Given this list of marker genes Pycr3, Gls2, Glul, Pycr2, Cln3, Pycr1, Agmat, Gls, Arg1, Ass1, Ldc1, Mecp2, Otc, Hal, Atcay (ataxia, cerebellar, Cayman type), Slc38a1, Nags, Bloc1s6, Noxred1, Cps1, Dao, Adhfe1, Got1, Nos3, Odc1, Mthfsl, Nit2, Amdhd1, Fah, Phgdh, Fpgs, Aldh4a1, Apc, Slc7a11, Gclc, Prodh, Nos2, Asl, Uroc1, Prodh2, Ppat, Pfas, Tat, Azin1, Azin2, Ddah1, Ucp2, Got2, Nos1, Asrgl1, Nr1h4, Ftcd, Lgsn, Atp2b4, Gclm, Gfpt2, Gad1, Arg2, Oat, Gad2, Sirt4, Glud1, Slc25a12, Cad, Ggt1, Aldh5a1, Aldh18a1, Aadat, Dglucy, here is a description of the gene set: The chemical reactions and pathways involving amino acids of the glutamine family, comprising arginine, glutamate, glutamine and proline. Mouse Gene Set: GOBP_GLUTAMINE_FAMILY_AMINO_ACID_METABOLIC_PROCESS species: Mus musculus